Given this list of marker genes PIGB, ALG1L2, TMTC4, TMEM260, DPY19L2P2, PIGZ, POMT1, ALG11, DPY19L1, DPY19L2, ALG12, PIGM, ALG1, ALG2, ALG9, POMT2, TMTC2, TMTC1, GTDC1, TMTC3, ALG3, DPY19L4, DPY19L3, DPM1, PIGV, here is a description of the gene set: species: Homo sapiens Catalysis of the transfer of a mannosyl group to an acceptor molecule, typically another carbohydrate or a lipid. Human Gene Set: GOMF_MANNOSYLTRANSFERASE_ACTIVITY